The following is a description of a gene set: Human Gene Set: WU_HBX_TARGETS_3_DN studied in species Homo sapiens Genes down-regulated by expression of HBV X protein (HBVgp3) both in SK-Hep-1 cells (hepatocellular carcinoma) and normal primary hepatocytes. from publication Wu CG, Salvay DM, Forgues M, Valerie K, Farnsworth J, Markin RS, Wang XW (PMID 11439330) Hepatitis B virus (HBV) is a major risk factor for the development of hepatocellular carcinoma (HCC). HBV encodes the potentially oncogenic HBx protein, which mainly functions as a transcriptional co-activator involving in multiple gene deregulations. However, mechanisms underlying HBx-mediated oncogenicity remain unclear. To determine the role(s) of HBx in the early genesis of HCC, we utilized the NCI Oncochip microarray that contains 2208 human cDNA clones to examine the gene expression profiles in either freshly isolated normal primary adult human hepatocytes (Hhep) or an HCC cell line (SK-Hep-1) ecotopically expressing HBx via an adenoviral system. The gene expression profiles also were determined in liver samples from HBV-infected chronic active hepatitis patients when compared with normal liver samples. The microarray results were validated through Northern blot analysis of the expression of selected genes. Using reciprocally labeling hybridizations, scatterplot analysis of gene expression ratios in human primary hepatocytes expressing HBx demonstrates that microarrays are highly reproducible. The comparison of gene expression profiles between HBx-expressing primary hepatocytes and HBV-infected liver samples shows a consistent alteration of many cellular genes including a subset of oncogenes (such as c-myc and c-myb) and tumor suppressor genes (such as APC, p53, WAF1 and WT1). Furthermore, clustering algorithm analysis showed distinctive gene expression profiles in Hhep and SK-Hep-1 cells. Our findings are consistent with the hypothesis that the deregulation of cellular genes by oncogenic HBx may be an early event that favors hepatocyte proliferation during liver carcinogenesis., and this is the list of marker genes: GLG1 (golgi glycoprotein 1), GAS6, GSTM4, MAP2K2, IL6 (interleukin 6), TGFB1, PMAIP1, GSTM5, TP53, WT1, GSTA4, PAK1, EBI3